Given this list of marker genes Fpr-rs7, Tm2d1, Lrp8, Apbb2, Fbxo2, Clstn1, Fpr3, Apbb1, Pfdn5, Hba-a1, Ngfr, Ldlr, Itga2, Cd36, Fpr-rs3 (NCBI Gene Id 14290), Itm2c, Chrna7, Cd74, Fzd5, Cst3, Gria3, Pirb, Ide, Hsd17b10, Bace1, Fpr2, Col25a1, Ephb2, Cryab, Fzd4, Pfdn2, Itm2a, Atp1a3, Gria2, Grin1, Pfdn1, Tlr2, Fpr-rs6, Ldlrap1, Itgb2, Fcgr2b, Insr, Apoa1, Clu, Pfdn4, Prnp, Itgb2l, Apba1, Adrb2, Apbb3, Gsap, Vbp1, Apba2, Calcr, Msr1 (NCBI Gene Id 20288), Gria1, Apoe, Apba3, Sorl1, Itm2b, Gprasp2, Fpr-rs4, Tgfb2, Pfdn6, Dlgap3, Marco, Ldlrad3, Ager, Trem2, Scarb1, here is a description of the gene set: Mouse Gene Set: GOMF_AMYLOID_BETA_BINDING studied in species Mus musculus Binding to an amyloid-beta peptide/protein.